The following is a description of a gene set: Histone methyltransferases catalyze site-specific deposition of methyl groups, enabling recruitment of transcriptional regulators. In mammals, trimethylation of lysine 4 in histone H3, a modification localized at the transcription start sites of active genes, is catalyzed by six enzymes (SET1a and SET1b, MLL1–MLL4) whose specific functions are largely unknown. By using a genomic approach, we found that in macrophages, MLL4 (also known as Wbp7) was required for the expression of Pigp, an essential component of the GPI-GlcNAc transferase, the enzyme catalyzing the first step of glycosylphosphatidylinositol (GPI) anchor synthesis. Impaired Pigp expression in Wbp7-/- macrophages abolished GPI anchor-dependent loading of proteins on the cell membrane. Consistently, loss of GPI-anchored CD14, the coreceptor for lipopolysaccharide (LPS) and other bacterial molecules, markedly attenuated LPS-triggered intracellular signals and gene expression changes. These data link a histone-modifying enzyme to a biosynthetic pathway and indicate a specialized biological role for Wbp7 in macrophage function and antimicrobial response. Human Gene Set: GSE30971_2H_VS_4H_LPS_STIM_MACROPHAGE_WBP7_KO_DN species: Homo sapiens from publication Austenaa L, Barozzi I, Chronowska A, Termanini A, Ostuni R, Prosperini E, Stewart AF, Testa G, Natoli G (PMID 22483804) Genes down-regulated in bone marrow-derived macrophages with MLL4 knockout: 2h LPS versus 4h LPS., and this is the list of marker genes: MPG, ID3, CCN2, GLI1, ADCY10, MTTP, MRPS15, CAST, CYP4X1, RPL24, ZNF518A, XIRP1, TMEM119, KCNE5, MRC2, LTA4H, LPCAT3, RPUSD3, MYC (NCBI Gene Id 731404), SLC22A12, ISLR, EXOC3L2, NUP210, OTULINL, SLC26A1, ATP1B3, CLPB, MCL1, XIST, INO80, SLCO5A1, C1QBP, AKR1B1, SLC12A6, CCNE1, METTL22, C14orf180, METTL24, HADHB, LARGE1, SLC7A8, NOL7, GASK1B, WDR82, ENTPD4, MROH1, KBTBD13, ASH1L, ETFBKMT, IGDCC3, CD247, C16orf54, TOP2B, MUTYH, PPP1R14B, CXCL12, SUCNR1, RAB3C, SPEG, MPI, PGPEP1L, MEP1B, THUMPD2, RBFOX3, CDC42SE2, PDHA1, LINC01160, ALDH2, SEPTIN10, ITGB1, LDLR, CYP4B1, ENOX1, ANXA6, IRX1 (NCBI Gene Id 79192), PDZD4, TBC1D21, C1orf50, CD70, CDC25B (NCBI Gene Id 994), FERMT2, HSD17B14, NMNAT3, SELENOP, KPLCE, TBKBP1, CCL19, ZFP36, RBM15B, CDC20B, IL36RN, C9orf85, PHLDA2, EEF1B2, PRSS41, NOD1, GLCCI1, TRAIP, LRRC47, NARS2, MTHFD1 (methylenetetrahydrofolate dehydrogenase, cyclohydrolase and formyltetrahydrofolate synthetase 1), CCN3, AP3M2, MC5R, BCL11B, ARL1, ABTB2, NRP1, PRKAR2B, APEX1, GDF9, PRLR, ADD1, MRPL12, CCDC126, SLFN12, MAGEB5, SPTA1, IGSF6, F8, LAMTOR2, C5orf63, TUSC2, CLDN16, MOSPD3, CFLAR, FGF18, FGB, VPS26A, KANSL1L, SLC25A45, RAB22A (RAB22A, member RAS oncogene family), ADAD1, KLHL30, ST18, IFI27L2, RHBDL1, TENT5C, SF3A2, PTGER4, LIPH, NEK7, SDAD1, RTN1, TIGAR, SLC22A5, OC90, HEXB, FMOD, NCKAP5, ANKH, OPRD1 (NCBI Gene Id 4985), NYNRIN, CYP27A1, HIF3A, CTNS, CNN1, IKZF1, ARPP21, THEMIS, IFT80, IRAG2, SNRPN, USP31, DHX38, LMAN1L, GNA14, CLYBL, C1orf198, DCTN6, CYB5A, MTLN, NXF3, CARTPT, ASIC1, BRINP1, RPUSD1, HOOK1, SCN1B, ZYG11A (zyg-11 family member A, cell cycle regulator), PRDM6, CHADL, GYG1, EEF1D, ARL4D, DIO2, ARK2N, FRMD4A (NCBI Gene Id 55691), SHTN1, ARHGEF26, KIAA0040, SRD5A1, GPR101, HSD17B2, PSMA6 (proteasome 20S subunit alpha 6), PDGFRB, CIMIP5, RSPH6A, ATIC, C8orf74